Given this list of marker genes Aoc1l3, Aoc1l2, Loxl4, Loxl3 (NCBI Gene Id 16950), Aoc1l1, Lox, Loxl1, Loxl2, Aoc1, here is a description of the gene set: Catalysis of the reaction: a diamine + H2O + O2 = a monoamine + NH4+ + H2O2. species: Mus musculus Mouse Gene Set: GOMF_DIAMINE_OXIDASE_ACTIVITY